Given this list of marker genes TAT, RNU4ATAC, KRT83, ARID2, KDF1, GJB2, WNT5A, BMPER, ANTXR1, ARID1B, WRAP53 (NCBI Gene Id 55135), SMARCA2 (NCBI Gene Id 95083), BICRA, CLIP2, JUP, CTC1, GLI1, ATP2A2, ERCC2, RTEL1, ORC1, MARS1, TGM1, ALG3, WNT7A, SIK1, CERS3, SMARCA4, ITGA3, FLNB, PARN, TP63, KDSR, LIG4, PRR12, KIF15, CTBP1, STING1, CCDC32, ALDH3A2, NSUN2, SHOC2, COL17A1, TWIST2 (NCBI Gene Id 117581), MPLKIP, GJB6, TRPS1, EZH2, ACAN, CD28, DPYD, GPC4, WRN, DYNC2LI1, KRT81, HYMAI, ZMYM2, SET, ZNF141, NDUFB11, FLNA, CWC27, MAP2K1, CDH1, SDR9C7, MAP3K20, ABCA12, APC (NCBI Gene Id 324), RFC2, WDR73, KRT9, NSD1, FBXO28, MEG3, IFNG, PERP, TCTN3, MAF, LAMB3, NPM1, CDH3, ABCA1, IL36RN, EGFR, CPT2, GLI3, COX7B, ECE1, TOMM7, AQP5, ZIC3, DNAJC21, SCN9A, INSR, PRKD1, RAF1, PIGN, DKC1, TINF2, CSTA, WDR19, RTL1, ACD, ARID1A, TCF4, NSD2, TBC1D24, SLCO2A1, SMARCAD1, FERMT1, KRT86, RAB7A, COL11A2, MMP1, SMARCB1, HEPHL1, TARS1, CYB5R3, DSP, TSC1, MAP2K2, GRM7, PHYH, LIPH, TRAF3IP2, HLA-C, ITGA6, PNPLA1, DPM1, RNF113A, RNF13, DPF2, FOXP3, FGFR3, RIPK4, PLCD1, RECQL4, CPLX1, PQBP1, KLHL24, FGFR2, ST14, NHP2, DVL3, EDAR, DSG4, PEX6, PIGB, CENPT, KRAS, ANAPC1, KCNH1, VEGFC, PPM1D, ODC1, LMX1B, ATP6V0A2 (NCBI Gene Id 7854), UMPS, HCCS, AARS1, KRT74, RERE, KCTD1, PI4KA, FGF9, TBL2, SMARCE1, GABBR1, HGD, FOXN1, IFT52, BANF1, DMXL2, SULT2B1, BAZ1B, SPEN, BMPR1B, VAC14 (VAC14 component of PIKFYVE complex), PITX1, SCN1B, WLS, PLEC, WDR35, H3-3B, TSPAN7, SOST, IGF2, GNAO1 (NCBI Gene Id 2775), EPS8L3, MLXIPL, DPH2, FKBP6, PAX9, SASH1, ACVRL1, STIM1, NECTIN1 (NCBI Gene Id 84853), ADAMTSL2, KDM1A, GJC2, TBX3, GJB4, ENG, KMT2D, TBX4, PEPD, GDF5, CTNND1, B3GALT6, RAB3GAP2, EVC2 (EvC ciliary complex subunit 2), RAB3GAP1, KIF1A, RECQL, PGAP2, NIPAL4, PTDSS1, RLIM, STXBP1, SHANK3, TRRAP, PIGQ, STAMBP, NFKB2, NOTCH2, LRP4, LIMK1, SLC25A24, AP1B1, DPYSL5, ARHGAP31, CDSN, GTF2I, IFT122, SIAH1 (siah E3 ubiquitin protein ligase 1), ACTG2, FAM111B, BLM, AFF4, ATR, NPR2, PSENEN, AAGAB, WNK1, FIG4, FOSL2, IHH, ERI1, TYMS, CYP4F22, FHL1, KIF11, BUD23, CCDC22, PIGO, AHDC1, CRKL, PLAG1, EFNB1, PLOD3, EOGT, COL7A1, TET2, ENPP1, UBAP2L, ALOXE3, POLD3, KCNN3, SF3B1, SLC24A4, DVL1, ELN, SLC39A4, EBP, OTUD5, CYB5A, SMARCD1, GTF2H5, LORICRIN, BCR (BCR activator of RhoGEF and GTPase), UBE2A, HR, RBCK1, AKT1, CLEC7A, RPA1, SUZ12, BHLHA9, TRPV3, TNFRSF1B, MVK, LMNA, KRT10, RPL21 (NCBI Gene Id 6144), CSTB, ARX, POC1A, GRHL2, MCTP2, MTX2, PEX7, POGLUT1, IL17RC, GNA11, CASR, SOX11, SHOX, FOCAD, PPP1CB, FZD6, ATL1, COL14A1, IL11RA, FTO, APC2, SETBP1, PIGF, EDARADD, TREX1, LAMC2, DNA2, TAF1, RBBP8, CDKN1C, RSPO1, KRT6B, ATP6V1B2, PEX1, GTF2IRD1, CTLA4, RBPJ, IRF6, TMEM270, ITGB4, PIGV, KRT1, UBR1, NOTCH1, MBTPS2, MYOF, KRT6A (NCBI Gene Id 93086), LAMA3, EDA, TMEM222, KCNA1, IL17RA, ERCC3, ACTL6B, LETM1, DST, ADAM17, GRIN1, IKBKG, SATB2, TMPRSS6, ZMPSTE24, IFT43, ASPRV1 (NCBI Gene Id 151516), KLK11, NEUROD2, ALG12, DLK1, FZD2, HOXC13, DPH1, CEBPE, FTL, RNU4-2, PEX2, GTF2E2, VPS37D, TGM5, EIF5A, PIGW, POLR3A, POMP, SOX4, SOX9, NOP10, EBF3, RNU12, HPGD, METTL27 (methyltransferase like 27), SREBF1, TFAP2A, DSC3, SLC32A1, KRT16, ALOX12B, SCN2A, HOXA13, NLRP1 (NCBI Gene Id 82286), TWIST1, DLL4, ANGPT2 (NCBI Gene Id 285), KRT5, STX1A, TERT, FRAS1 (Fraser extracellular matrix complex subunit 1), DHX37, MSX1, ADA2, NXN, SRY, FGFRL1, GJB3, CAMK2G, TRAF6, RPS6KA3 (NCBI Gene Id 6197), SLURP1, PPP1R13L, GJA1, PGAP3, KANK2, PIGA, POLR1A, SLC25A22, EXT2, NFKBIA, CDIN1, HRAS, LPAR6, STK11, BMP4, INPPL1, SOX18, FGFR1, SIN3B, IL17F, FUCA1, BMP2, PIGL, NEPRO, KRT17, RETREG1, SMARCC2, TERC, RUNX2, GTF2IRD2, SLC35D1, RSPO4, NSDHL, COL11A1, NTRK1, ZNF462, PRKACA, AIRE, ZFX, TRIM8, DSG1, BRAF, EIF4H, PLAGL1, CASK, PIGY, TELO2, TSC2, CKAP2L, PIEZO1, APCDD1 (APC down-regulated 1), SIN3A, PRKAR1A, WNT10A, FGF10, SMARCD2, STAT3, CAST, DOCK6, VPS35L, PPP2R5D, ANGPT1, ROR2, POP1, ZSWIM6, KRT14, DLX3, DNAJC30, AP1S3, USB1, UFC1 (NCBI Gene Id 51506), FLT4, WASHC5 (NCBI Gene Id 9897), IFIH1, PRKACB, SCO2, HMGA2, CAMK2B, FOXC2, NCF1 (neutrophil cytosolic factor 1), UROD, EED, CD151, HUWE1, PKP1, GPC3, CARS1, CTSK, NAF1, HHAT, PNKP, ZBTB20, CTSC, CARD14, EVC, TP53, LIPN, LSS, PORCN, KRT85, HLA-B, TTC7A, MACROH2A1, PIGP, ADNP, GSN, DCLRE1B, CDKL5, NOG, POFUT1, NECTIN4, MAPK1, PDE4D, here is a description of the gene set: Abnormal nail morphology Human Gene Set: HP_ABNORMAL_NAIL_MORPHOLOGY Abnormal structure or appearance of the nail. species: Homo sapiens